The following is a description of a gene set: species: Homo sapiens Human Gene Set: HP_FOCAL_NON_MOTOR_SEIZURE Focal non-motor seizure A type of focal-onset seizure characterized by non-motor signs or symptoms (or behavior arrest) as its initial semiological manifestation., and this is the list of marker genes: PHGDH, PI4KA, TBC1D24, SCN2A, LGI1, KCNA1, KCNQ3, PIGA, AHDC1, ATP1A2, SMO, GLI3 (NCBI Gene Id 2737), SLC38A3, NPRL2, PDE2A, TREX1, SCN1A, SLC25A22, SRPX2, SLC12A5, EPM2A, EIF4A2, KCNT1, KCNQ2, PCDH19, SCN8A, ADGRG1, CNTNAP2, NGLY1, CNTN2, RELN, PRRT2, DEPDC5 (DEP domain containing 5, GATOR1 subcomplex subunit), NHLRC1, MTHFS, PACS1, PLCB1, NPRL3, CACNA1A, GRIN1, GAL, MICAL1